The following is a description of a gene set: Mouse Gene Set: GOBP_REGULATION_OF_CILIUM_ASSEMBLY Any process that modulates the frequency, rate or extent of cilium assembly. species: Mus musculus, and this is the list of marker genes: Limk2, Tapt1, Atg5, Odf2, Ift20 (NCBI Gene Id 68335), Intu, Tchp, Wrap73, Yap1, Tbc1d7, Lima1, Dcdc2a, Akt1, Noto, Saxo1, Septin9, Ppp1r35, Ccdc88a, Ccp110, Marchf7 (membrane associated ring-CH-type finger 7), Sdccag8, Hap1 (huntingtin-associated protein 1), Htt, Bbs4, Dnm2, Arhgap35, Kctd17, Pqbp1, Evi5l, Mark4, Gsk3b (NCBI Gene Id 98033), Kif24, Syne2, Mir129-2, Zmynd10, Ttbk2, Syne1, Cntrob, Odf2l, Cep120, Ift140, Arf4, Cdkl1, Fuz, Wdr44, Mak, Cenpj, Crocc, Odad3, Mphosph9, Cdkl5, Gdi2, Rab11a, Trim32, Cep135, Entr1, Tesk1, Rab11fip3, Atg3, Mns1, Dynlt2b, Dynll1, Dync2li1, Mapk15, Tmem67, Tbc1d30, Rabep2, Luzp1, Dzip1, Mcidas, Rp1, Lpar1, Cep97, Ift88, Adamts16, Cyld, Wdpcp, Rab3ip, Cdk10, Atmin, Ift46